Given this list of marker genes Grk1 (G protein-coupled receptor kinase 1), Grk5, Grk3, Grk2, Grk6, Grk4, here is a description of the gene set: Catalysis of the reaction: ATP + G protein-coupled receptor = ADP + G protein-coupled receptor phosphate. studied in species Mus musculus Mouse Gene Set: GOMF_G_PROTEIN_COUPLED_RECEPTOR_KINASE_ACTIVITY